Given this list of marker genes NFAT5, GAS1, MLLT3, PAPSS2, TMCC3, APH1A, ARID1B, ZC4H2, CAMSAP2, IL1RAP, DLAT, NCOR1, RAB3C, BACE1, RALA, STK38L, SOX6, ANKS1B, PLEKHA1, FAM219A, MYC, PARD3, CELF2 (CUGBP Elav-like family member 2), NEUROD1, CNTNAP1, MYF5, HOXC8, RHOH, PUM1, QDPR, MAN2A2, DEFB134, DLL1, TENM1, MYCBP2, MTUS2, MTCL2, ATP1B3, GSK3B, HOXB8, LYST, ELAVL1, STMN2, XKR6, FKBP1B, CADM2, NHSL1, MTCL1, MIDEAS, ETS1, MTF1, GRHL1, HMBOX1, PHACTR1, ACTL6A, FBXO45, MAPK4, PYGB, NEXMIF, CELSR3, PFKFB1, TSPYL4, RFX3, JAKMIP1, AHCYL2, VAMP3, ASCL1, KCTD16, CEP55, MARVELD2, PRKAA2, ELMOD1, TMEM19 (NCBI Gene Id 55266), RDX, CBLB, PIK3C2A, MAPK1IP1L, PIEZO2, CREB1, GTF3C2, HTR2C (5-hydroxytryptamine receptor 2C), MAP3K9, STK39, PHF6, THRB, DAAM1, FUT9, THAP12, HMGN4, WIPF3, LCP1, CDK19, PTPN4, APOB, CTNND2, DENND1B, TFDP2, SNIP1, ADD2, FBXO40, DLG1, NDRG1, TOX, ZNF597, KCNA1, BRPF1 (NCBI Gene Id 7862), ATP11C, CD40LG, TENT4A, CALN1, ARID2, SLC25A13, PTPRG, ATP6V0A2, USP15, ATAD2B (ATPase family AAA domain containing 2B), CLDN8, MTDH, here is a description of the gene set: species: Homo sapiens from publication Chen Y, Wang X (PMID 31504780) Genes predicted to be targets of miRBase v22 microRNA hsa-miR-2682-5p in miRDB v6.0 with MirTarget v4 prediction scores > 80 (high confidence targets). Human Gene Set: MIR2682_5P